Given this list of marker genes Fmn1, Adipoq, Pdgfra, Lamb2, Aqp1, Grem1, Osr1, Pkd1, Egr1, Irx2, Irx1, Nphs2, Tcf21, Lif, Lgr4, Ret, Bmp4, Hes1, Tfap2b, Cd34, Kif26b, Gdnf, Wt1, Stat1, Hes5, Foxd1, Sall1, Cited1, Sox8, Pdgfrb, Tfap2a, Wnt9b, Six2, Pkd2, Wnt4, Lhx1, Smo, Pax8, Sox9, Pdgfb, Pax2, Agtr2, Ctnnb1, here is a description of the gene set: The process whose specific outcome is the progression of a nephron in the metanephros over time, from its formation to the mature structure. A nephron is the functional unit of the kidney. studied in species Mus musculus Mouse Gene Set: GOBP_METANEPHRIC_NEPHRON_DEVELOPMENT